The following is a description of a gene set: Neutrophilic infiltration of the skin A predominantly neutrophilic infiltrate of the dermis and or epidermis (i.e., a large number of neutrophils inferred to have migrated into the skin). Human Gene Set: HP_NEUTROPHILIC_INFILTRATION_OF_THE_SKIN studied in species Homo sapiens, and this is the list of marker genes: MEFV, LDHA, PTPN6, POMP, UBA1, DOCK11